Given this list of marker genes LYRM4, NFS1, MOCS2, FXN, ISCU, CTU1, NDUFAB1, here is a description of the gene set: A protein complex capable of catalyzing the transfer of sulfur atoms from one compound (donor) to another (acceptor). Human Gene Set: GOCC_SULFURTRANSFERASE_COMPLEX species: Homo sapiens